Given this list of marker genes Kif24, Atxn7, Arpc2, Plek, Rdx, Cib1, Cfl2 (NCBI Gene Id 12632), Ccdc88c, Sh3bp1, Htt, Trim54, Camsap1, Gsn, Add3, Lima1, Ccsap, Tmod4, Hdac6, Kif2b, Cracd, Gas2l2, Nckap5l, Eps8, Arhgef1, Trpv4, Bbof1 (basal body orientation factor 1), Gas2l1, Twf2, Avil (NCBI Gene Id 11567), Clasp1, Capza2, Dnajc6, Nav3, Map1s, Gak, Cltc, Carmil2, Spef1, Sptb, Svil, Smn1, Katnb1, Flii, Diaph3, Stmn2, Plekhh2, Apc2, Sptbn1, Hdgfl3, Dbnl, Hspa8, Actn2, Nedd1, Map2, Fgf13, Dmtn, Synj1, Tpx2, Htr1a, Map1b, F2rl1, Mid1ip1, Arhgef2, Wdr1, Stmn1, Lmod3, Map1a, Rhoa, Capzb, Myh9, Mtpn (myotrophin), Ckap2, Kif18b, Nckap5, Kif2c, Ppp1r9b, Mid1, Capza1 (capping actin protein of muscle Z-line subunit alpha 1), Add2, Wdr47, Pik3ca, Tmod3, Camsap3, Dstn, Evl, Aurkb, Lmod1, Twf1, Mical1, Apc, Cfl1, Rp1, Tmod2, Clasp2, Mical2, Swap70, Vill, Kif14, Nes, Scin, Stmn3, Camsap2, Kif19a, Bmerb1, Spta1, Ccn2, Capza1b (capping actin protein of muscle Z-line subunit alpha 1B), Kif21a, Map6d1, Taok1, Capza3, Sema5a, Sgk1, Eml4, Spast, Ttbk2, Add1, Aqp2, Pdxp, Mical3, Asph, Shroom2, Vps4a, Lmod2, Specc1l, Stmn4 (NCBI Gene Id 97941), Capg, Sptan1, Vil1, Kif18a, Tpm1, Vps4b, Tmod1, Carmil1, here is a description of the gene set: Mouse Gene Set: GOBP_PROTEIN_DEPOLYMERIZATION studied in species Mus musculus The process in which protein polymers, compounds composed of a large number of component monomers, are broken down. Depolymerization occurs by the successive removal of monomers from an existing poly- or oligomeric protein.